Given this list of marker genes LAMTOR3, MIR224, SPAAR, BCL11A, SLC7A5, PDGFC, GLRA1, NFE2L2, RBX1, PRMT1, SH3BP4, MIR545, SESN2, EP300, UBR1, BAIAP2, LARS1, HNRNPD, DNMT1, MTOR, SESN3, IPO5, ASS1, COL3A1, PIK3CA, KLHL22 (NCBI Gene Id 84861), STAMBPL1, SIPA1, XBP1, MMP2, RRAGD, LAMTOR1, SIX1, LAMTOR5, MIR421, HNRNPAB, CPEB1, CASTOR1, MMP3, MIR455, COL6A1, ABCB1, HSF1, RRAGC (Ras related GTP binding C), GCLM, CUL3, COL1A1, PNPLA3, GCLC, COL1A2, RRAGA, PKD2, MAT2A, CAPN2, LAMTOR2, RPTOR, MIR95, FYN, COL4A1, NSMF, DNMT3A, ZEB1, PDGFRA (NCBI Gene Id 5156), GRIN2D, SAMTOR, GRIA1, HPCA, CASTOR3P, COL16A1, GLRA2, PDGFD, AVPR1A, PRKN, SLC38A9 (NCBI Gene Id 153129), AMIGO1, BCL2L1, AQP2, EGFR, CPEB3, VEGFA, LAMTOR4, PLEC, NEURL1, CASTOR2, CEBPB, COL4A6, CPEB4 (NCBI Gene Id 80315), NTRK2, MIR92A1, KLF2, SESN1, CYBA, CYBB, TNF, HMGCS2, UBR2, MIR342, MIR762, RRAGB, SOCS1, COL5A2, here is a description of the gene set: Any process that results in a change in state or activity of a cell (in terms of movement, secretion, enzyme production, gene expression, etc.) as a result of a stimulus by the chemical structure of the anion portion of the dissociated acid (rather than the acid acting as a proton donor). The acid chemical may be in gaseous, liquid or solid form. species: Homo sapiens Human Gene Set: GOBP_CELLULAR_RESPONSE_TO_ACID_CHEMICAL